The following is a description of a gene set: Mouse Gene Set: GOBP_RADIAL_GLIA_GUIDED_MIGRATION_OF_PURKINJE_CELL studied in species Mus musculus The migration of postmitotic a Purkinje cell along radial glial cells from the ventricular zone to the Purkinje cell layer., and this is the list of marker genes: Dab1, Ctnna2, Cul5, Rnf7, Rere, Socs7, Rbfox2